Given this list of marker genes Rps23, Rpl34, Eif4g1, Rpl35rt, Rpl22, Rps27l, Rplp0, Rpl23, Fau, Rps21, Rpl32, Rpl6, Rps27a, Rps24, Rpl18, Rpl9, Rps29, Gm6525, Rplp1 (ribosomal protein lateral stalk subunit P1), Rps15a, Rpl12, Gspt1, Rpl4, Rpl36a-ps1, Rps15, Rpl3, Rps27 (NCBI Gene Id 69272), Rps17, Rps3a1, Rpl22l1, Rpl37, Rps27rt (NCBI Gene Id 634885), Rpl10, Rpl8, Rps28, Uba52rt, Rpl10-ps3, Rpl15, Rps9, Rpl37a, Rpl7, Upf1, Uba52, Rpl39, Rps4x, Rpl30 (ribosomal protein L30), Rps16, Rps12, Rpl21, Rpl17, Rpl38, Etf1, Rpl31, Rpl36a, Rpl14, Rpl18a, Rpl23a, Rpl36, Rps26, Rps3 (NCBI Gene Id 52418), Rps5, Rpl35, Rpl19, Rps7, Rpl28, Rpsa, Ncbp1, Rpl24, Rps11, Rpl5, Rpl35a, Pabpc1, Rps14, Rpl11, Rpl27a (ribosomal protein L27A), Rpl3l, Rps20, Rpl29, Rpl13a, Rpl27, Gspt2, Rplp2, Rps18, Rpl7a, Rps6, Rpl13, Rpl26, Rps10, Rps13 (NCBI Gene Id 68052), Rps2, Rpl36al, Rps19, Rps25, Rps8 (NCBI Gene Id 20116), Ncbp2, Rpl39l, Rpl10l, here is a description of the gene set: species: Mus musculus Nonsense Mediated Decay (NMD) independent of the Exon Junction Complex (EJC) Mouse Gene Set: REACTOME_NONSENSE_MEDIATED_DECAY_NMD_INDEPENDENT_OF_THE_EXON_JUNCTION_COMPLEX_EJC